Given this list of marker genes LINC01686, ADAMDEC1, CSF1, TNC, LRRC37A17P (leucine rich repeat containing 37 member A17, pseudogene), PTGDS, NPFFR1, LINC02196, DAZL, MINCR, HTD2, VCAM1, CYP51A1P2, COL6A5, ENSG00000227531, APOE, PJVK, OLA1P1, C1S, CXCL13, GRIN2B, HS3ST6, IGFN1, MYBPC2, PI15, MSC, ENSG00000226706, FGF11, LINC02350, CXCL14, C1GALT1C1L, SNORD116-30, RPL27P6, PTGER1, CILP2, ADGRF1, PCDH11Y, EIF5-DT, OCA2, TNFSF11, COL7A1, TNFRSF11B, CDX1, SPIC, CCL19, TPBGL (NCBI Gene Id 441617), ALPK2, UBD, FMO6P, GAL3ST3, AARD, SHISA3, PCDH11X, CCL21, LGI2, WDR97, CXCL12, HOXC9, PRPS2, SLC22A3, MIR3677HG, KPNA2P2, PGF, LPAL2, FDCSP (follicular dendritic cell secreted protein), ADM2, SLC26A7, FNDC1-AS1, here is a description of the gene set: species: Homo sapiens The gene expression program underlying the specification of human cell types is of fundamental interest. The study authors generated human cell atlases of gene expression and chromatin accessibility in fetal tissues. For gene expression, the study authors applied three-level combinatorial indexing to >110 samples representing 15 organs, ultimately profiling ~4 million single cells. The study authors leveraged the literature and other atlases to identify and annotate hundreds of cell types and subtypes, both within and across tissues. Our analyses focused on organ-specific specializations of broadly distributed cell types (such as blood, endothelial, and epithelial), sites of fetal erythropoiesis (which notably included the adrenal gland), and integration with mouse developmental atlases (such as conserved specification of blood cells). These data represent a rich resource for the exploration of in vivo human gene expression in diverse tissues and cell types. Marker genes curated from the annotated cluster as represented in the Descartes Human Gene Expression During Development database. Human Gene Set: DESCARTES_FETAL_PANCREAS_CCL19_CCL21_POSITIVE_CELLS from publication Cao J, O'Day DR, Pliner HA, Kingsley PD, Deng M, Daza RM, Zager MA, Aldinger KA, Blecher-Gonen R, Zhang F, Spielmann M, Palis J, Doherty D, Steemers FJ, Glass IA, Trapnell C, Shendure J (PMID 33184181)